The following is a description of a gene set: species: Homo sapiens Any process that activates or increases the rate or extent of glial cell proliferation. Human Gene Set: GOBP_POSITIVE_REGULATION_OF_GLIAL_CELL_PROLIFERATION, and this is the list of marker genes: LTA, MYB, GFAP, MECP2, KRAS, TSPO, NTN1, MIR221, ATXN1, MIR222, ETV5, PPP1CC, MIR125B1, IL6, PRKCH, UFL1, IL1B, PRKCI, VEGFC, TNF, E2F1, PLAG1, SLC7A5, LYN